The following is a description of a gene set: Genes specifically up-regulated in Cluster IIb of urothelial cell carcinom (UCC) tumors. species: Homo sapiens We used gene expression profiling, mutation analyses of FGFR3 and TP53, and LOH analyses of chromosome 9 and the TP53 region on chromosome arm 17p, to molecularly characterize 75 Ta and T1 bladder carcinomas. We identified four major cellular processes related to cell cycle, protein synthesis, immune response, and extra cellular components that contribute to the expressional heterogeneity of early-stage urothelial cell carcinoma (UCC). Activating FGFR3 mutations were found at the highest frequency in G1 tumors (80%), and showed a strong correlation with FGFR3 expression. In contrast, G3 tumors displayed mutations in less than 10% of the cases and a low level of FGFR3 expression. Even though LOH on chromosome 9 was not associated with any specific expression pattern, our data indicate that loss of chromosome 9 is associated with tumor development rather than initiation. The combined analyses suggest the existence of two types of UCC tumors, one which is characterized by FGFR3 mutation or expression, high expression of protein synthesis genes, and low expression of cell cycle genes. Furthermore, the presented data underscore FGFR3 receptor involvement in urothelial cell transformation as the presence of FGFR3 mutations has a major impact on the global gene expression profile of bladder carcinomas. Human Gene Set: LINDGREN_BLADDER_CANCER_CLUSTER_2B from publication Lindgren D, Liedberg F, Andersson A, Chebil G, Gudjonsson S, Borg A, Månsson W, Fioretos T, Höglund M (PMID 16532037), and this is the list of marker genes: PREX1, RGS2, MS4A4A, PHTF2, SLC16A2, PNOC, EMP3, DNAJB5, RGS10, ADAMTS9, ATP1A2, GLIPR1, PDPN (NCBI Gene Id 29912), ITGA4, PRKAR1A, JUN, LMCD1, CDC42EP3, NFIL3, ELN, GJA5 (gap junction protein alpha 5), SOX18, MFNG, YKT6, EGR1, LATS2, IQGAP2, MOXD1, CNRIP1, IGLL1, PIM2, EVI2B, FMNL1-DT, CELF2, TES, ZAP70, MT1E, THBS2, RCAN2, LYZ, TBC1D8, RBPMS2, COPZ2, C1S, PITX2, LBH, TMEM131L, PARVG, TSC22D3, NFATC1, RUNX3, PLAUR, CCL13, PODXL, DAAM2, STUM, SOCS2, NR4A1, FGL2, CNN3, SELL, KRR1, CXCR4, ABI3BP, TNS1, SAMSN1, IL1A, PALLD, AP1S2, EMC10, ALDH2, DKK3, GNG11, IL7R, MYO1F (myosin IF), TIMP2, PPP1R16B, SERPING1, ARHGAP30, CALM1, COG8, NR2F1, MSN, MYADM (myeloid associated differentiation marker), MYLK, PELI1, SERPINF1, VCAM1, SEMA6D, NFKBIZ, ETV1, COL16A1 (NCBI Gene Id 1307), PDE1A, FBLN2, EPB41L2, TMTC1, CHSY1, CH25H (NCBI Gene Id 9023), DUSP5, MPP1, LIG4, FCGR2B, GUCY1A1, LCP2, BCL2A1, TCF25, HYCC1, PRKCH, IFITM1, IL10RA, FERMT3 (FERM domain containing kindlin 3), EBI3, RARRES2, ITM2A, GPC6, ADGRE5, KLRK1, LUM, TACC1, EFHD1, IFITM2, DNAJB9, JAM3, PRICKLE1, IGDCC4, SON, COL1A2 (NCBI Gene Id 1278), CYBB (cytochrome b-245 beta chain), MAF, GRK5, MT1L, LRRC8C (NCBI Gene Id 84230), FLVCR2, COL6A2, AEBP1, RGL1, MAP1A, ECM2, ALOX5AP, FYN, MAP3K20, RNF41, ANXA6, CCN1, HHEX, FYB1, ICAM1, HLA-DRA, MT1X, SH2B3, EBF1, UBD, BRPF1, UBE2J1, SOCS3, AMOTL2, LAPTM5, RAC2, STMN3, ADAM19, LEF1, UBE2J2, COLEC12, IER2, PDGFRL, RUNX2, PDZRN3, HLA-DPB1, RPS19BP1, MMP2, AKAP12, ENTPD1, MT1H, RALB, POSTN, MALT1, DHRS12, LINC00472, SIRPA, CTSG, C1R, DHODH, RBP1, CFL2, ST6GAL1, B3GNT2, ITK, GFOD1, ARHGAP15, SELE, COL6A1, IFITM3, STXBP6, ZNF738, TPST1, TTC7A, SRPX, LCK, IGFBP7, CSRP1, COTL1, FAM200B, SLC2A4RG, DAB2, C3AR1, CXCL12, PTPN7, SLC7A2, MYO5A, SSR1, RTN3, NEK6 (NIMA related kinase 6), CMTR2, CRIP1, FOXF1, AIF1, TENT5C, SDC3, RAMP3, PPTC7, SH3KBP1, ARL4C, NUAK1, SERPINA3, TNC, LGALS1, THBD, NID2, PROS1, PCDH7, SYN3, HTRA3, AURKB, RGS11, PDGFRB, MPP3, ACTA2, NES, MCAM, CLIC4, MAFB, PNMA1, ADGRF5, TTN, TCF7, CCDC80, PECAM1, SPAG7, PXDN, EDIL3, NRN1, LAT2, HLA-DRB5, TNFAIP3, CCL2 (NCBI Gene Id 6347, C-C motif chemokine ligand 2), RBP5, SLFN11, NFKBIA, AFF1, MOB3B, FILIP1L, PCOLCE, NUMA1, TOX, ADORA2A, MAPK7, BMP2K, CD302, CLIC2, AQP1, HLA-DRB6 (major histocompatibility complex, class II, DR beta 6 (pseudogene)), PPP1R18, IL27RA, BMP5, COL15A1, HEYL, APLNR, GPM6B, KLRG1, RGS5, IL16, ANPEP, EFEMP1, EDNRA, MT1G, CAV1, BIRC3 (baculoviral IAP repeat containing 3), AOC3, LGALS2, SLC43A3, TGFBR1, JMJD7-PLA2G4B, CRTAM, COL5A2, JAK3, KLF4, ITGAL, GSN, IGLC1, PIK3CD, SPRY1, DDR2, PALM2AKAP2, SRGN, IL32, TPM2, CCN2, OSER1, HLA-DRB1, CRISPLD2, MT2A, PMP22, STOM, HLA-E, IFI30, SYNPO, PTK2, AKAP14, PPP1R12B, WHRN, S100A7, A2M, CERK (NCBI Gene Id 64781), CAVIN1, NEURL1B, DNAJC3, PRRX1, RELL1, PAPPA (pappalysin 1), GEM, TCF4, STARD4, ARPC2, CCL15 (C-C motif chemokine ligand 15), TMEM158, YWHAZ, HLF, COL6A3, IL2RG, ANGPTL2, ISG20, ZFAND5, CDC25B, TRAF1, MICAL2, MIAT, CLEC10A, LAMA4, PDGFRA (NCBI Gene Id 5156), KLHL6, LRIG1 (leucine rich repeats and immunoglobulin like domains 1), HMGCS1, SPARC, CCN3, SVEP1, MGP, NRP2, FHL1, GADD45B, TPM1, CD52, NFKBIE, LCP1, LAMB2, DDX3Y, CYTH4, FOLR2, DOCK2, HLA-DMA, CST7, LIX1L, CPXM1, SAMHD1, RNASE6, MYL9, RHOH, C4A, PCP4, CYBRD1, ACTG2, SREBF1, GLIPR2, HLA-DQB1, DPYSL2, EVI2A, C1orf54, COL18A1, RND3, NNMT